The following is a description of a gene set: species: Mus musculus Any process that modulates the size of a lysosome. Mouse Gene Set: GOBP_REGULATION_OF_LYSOSOME_SIZE, and this is the list of marker genes: Bloc1s2, Bloc1s1, Borcs5 (BLOC-1 related complex subunit 5), Kxd1, Borcs6, Borcs7, Borcs8, Snapin (SNAP-associated protein)